Given this list of marker genes IDH1, APOC2, PRKCD, ENPP7, SCARB1, LDLR, APOC1, here is a description of the gene set: Any process that modulates the rate, frequency, or extent of phospholipid catabolism, the chemical reactions and pathways resulting in the breakdown of phospholipids, any lipid containing phosphoric acid as a mono- or diester. species: Homo sapiens Human Gene Set: GOBP_REGULATION_OF_PHOSPHOLIPID_CATABOLIC_PROCESS